Given this list of marker genes Cd3e, H2-T23, Psme2, Tubb4b, Tmsb10, Pfn1, here is a description of the gene set: from publication Cui A, Huang T, Li S, Ma A, Pérez JL, Sander C, Keskin DB, Wu CJ, Fraenkel E, Hacohen N (PMID 38057668) Cytokines mediate cell-cell communication in the immune system and represent important therapeutic targets. A myriad of studies have highlighted their central role in immune function, yet we lack a global view of the cellular responses of each immune cell type to each cytokine. To address this gap, the authors created the Immune Dictionary, a compendium of single-cell transcriptomic profiles of more than 17 immune cell types in response to each of 86 cytokines (>1,400 cytokine-cell type combinations) in mouse lymph nodes in vivo. A cytokine-centric view of the dictionary revealed that most cytokines induce highly cell-type-specific responses. For example, the inflammatory cytokine interleukin-1β induces distinct gene programmes in almost every cell type. A cell-type-centric view of the dictionary identified more than 66 cytokine-driven cellular polarization states across immune cell types, including previously uncharacterized states such as an interleukin-18-induced polyfunctional natural killer cell state. Mouse Gene Set: CUI_T_CELL_CD8_IL17E_RESPONSE_UP studied in species Mus musculus Genes positively differentially expressed in cell type: CD8+ T cell upon treatment with cytokine: IL-17E in mouse lymph nodes in vivo.